The following is a description of a gene set: Mouse Gene Set: GOBP_NATURAL_KILLER_CELL_MEDIATED_IMMUNE_RESPONSE_TO_TUMOR_CELL An immune response mediated by a natural killer cell triggered in response to the presence of a tumor cell. species: Mus musculus, and this is the list of marker genes: Klrk1 (killer cell lectin-like receptor subfamily K, member 1), Cd226, Nectin2, Pvr, Il12a, Il12b, Klre1, Ceacam1, Cd160, Crtam, Nkg7, Tgfb1, Havcr2